Given this list of marker genes TBC1D2, LUC7L, SNX29, HIPK2, CEACAM1, PPP1R16A, CYFIP1, PTPRA, JUP, TIMM44, EMILIN2 (elastin microfibril interfacer 2), IL4R, PATL1, RRBP1, ATXN7L2, CCL18, MERTK, CDK5RAP2, here is a description of the gene set: Genes positively correlated with antibody response in blood in adults (18-40) after exposure to Sanofi Pasteur, SA, Inactivated influenza vaccine, time point 3D Identification of the host genetic factors that contribute to variation in vaccine responsiveness may uncover important mechanisms affecting vaccine efficacy. We carried out an integrative, longitudinal study combining genetic, transcriptional, and immunologic data in humans given seasonal influenza vaccine. We identified genes exhibiting a transcriptional response to vaccination, significant genotype effects on gene expression, and correlation between the transcriptional and antibody responses. The results show that variation at the level of genes involved in membrane trafficking and antigen processing significantly influences the human response to influenza vaccination. More broadly, we demonstrate that an integrative study design is an efficient alternative to existing methods for the identification of genes involved in complex traits. DOI:http://dx.doi.org/10.7554/eLife.00299.001. Human Gene Set: FRANCO_BLOOD_SANOFI_PASTEUR_SA_INACTIVATED_INFLUENZA_VACCINE_CORRELATED_WITH_ANTIBODY_RESPONSE_AGE_18_40YO_3DY_POSITIVE from publication Franco LM, Bucasas KL, Wells JM, Niño D, Wang X, Zapata GE, Arden N, Renwick A, Yu P, Quarles JM, Bray MS, Couch RB, Belmont JW, Shaw CA (PMID 23878721) studied in species Homo sapiens